Given this list of marker genes CHAF1A, RBBP4, H3-4, NASP, ASF1A, ASF1B, CHAF1B, here is a description of the gene set: studied in species Homo sapiens The formation of nucleosomes on newly synthesized DNA, coupled to strand elongation. Human Gene Set: GOBP_DNA_REPLICATION_DEPENDENT_CHROMATIN_ASSEMBLY